The following is a description of a gene set: Genes predicted to be targets of miRBase v22 microRNA mmu_miR_6363 in miRDB v6.0 with MirTarget v4 prediction scores > 80 (high confidence targets). studied in species Mus musculus from publication Chen Y, Wang X (PMID 31504780) Mouse Gene Set: MIR_6363, and this is the list of marker genes: Klhl31, Adgrb3 (NCBI Gene Id 210933), Rab5a, Creb1, Lrrcc1 (NCBI Gene Id 99624), Rfng, Nrbp1, Sgk3, Slc4a7, Hapln2, Gkap1, Prss59, Clstn2, Bmp2, Mrps36, Litaf, Bcar1, Foxp2, Il21, Uba6, Slc12a1, Zyg11b, Hmgb2, Sugp1, Tle1 (transducin-like enhancer of split 1), Ppat, Tkt, Ston2, Trp53tg5, Lsm14a, Rps27l, Fyb2 (FYN binding protein 2), Bmal2, Rpl15 (NCBI Gene Id 66480), Angpt1, Eif4g2